The following is a description of a gene set: from publication Chen Y, Wang X (PMID 31504780) Genes predicted to be targets of miRBase v22 microRNA mmu_miR_29a_5p in miRDB v6.0 with MirTarget v4 prediction scores > 80 (high confidence targets). Mouse Gene Set: MIR_29A_5P studied in species Mus musculus, and this is the list of marker genes: Lratd2, Commd6, B230219D22Rik, Ccdc34, Cdc37l1, Mfsd6, Ncor1, Cisd2, Erg, Gpr82, Zfp955b, Pla2r1, Slc12a2, Tbc1d1, Btnl2, Gpatch2, Lrrtm3, Lrrc38, Ahcyl2, Pak5, Trak2, Sox21, Slfn9, Onecut2, Spats2l (NCBI Gene Id 98693), Slc8a1, Hoxa10, Adgre4, Mapk6, Crisp4, Wnt5a, Trpm7, Odf2l, Plppr4, Lrrc34, Igfbp4, Elmod2, Fam110c, Letm1, Oga, Ccnk, Rab21, Hhip (Hedgehog-interacting protein), Kcna1, Evi2b, Agap1, G2e3, Iigp1c, Zxdb, Ipo5, Rpap2, Arid4b, Synpr, Tmed7, Ttc8, Nmnat2, Scai, Ptgr3, Afap1l1, Fgfbp3, Tbl1xr1, Nynrin, Tmem128, Cetn3, Znrf3, Pgrmc1, Cep135, Ahcyl1, Cdon, Dnai2, 1600012H06Rik, B3gat1, Gm1110, Mysm1, Ldb2 (LIM domain binding 2), Hnf4g, A1cf, Snrnp25, Bub3, Pigr, Sh3bp2, Slc45a3, Mfsd9 (major facilitator superfamily domain containing 9), Ttc14, Iqch, Rtraf, Epop, Atp6v1c1, Sema3e, Pdcl, Lama4, Ttpa, Prelid3b, Lpp, Insr, Kdm1b, Taf13, Fgf7, Kpnb1 (karyopherin subunit beta 1), Esyt3, Nr4a3, Cacnb4, Dcaf8l, Thap1, Azi2 (5-azacytidine induced gene 2), EU599041, Sap25, Scyl2, Hacd3, Mmab, Nap1l2, Iqgap2, Krt222, Aamdc, Eng, Rhoa, Rims2, Tm2d1, Znrf2, Dennd1b, Slco1a1, Galnt17, Neurod6, Ptcd3 (NCBI Gene Id 75421), Cab39 (NCBI Gene Id 98246), Acta2 (actin alpha 2, smooth muscle, aorta), Atrnl1, Thrb, Fbxw7 (NCBI Gene Id 68467), Gprc5b, Cyrib, Gsdma, Kat2b, Mtf2, Wt1, Camsap2, Ets1, Csmd1, Abhd10, Cenpf, Hycc2, D430041D05Rik, Bbc3, Hivep1, Rbm46 (RNA binding motif protein 46), Abraxas2, Vcf2, Robo1, Bicd1 (BICD cargo adaptor 1), Exoc5, Mei4, Rfc1